Given this list of marker genes CCDC32, ZIC3, CFAP53, CFC1, CIROP, PKD1L1, CPLX1, LETM1, PIGG, CLXN, TBX5, CFAP52, DAW1, ODAD4, NSD2, NELFA, SMAD2, FOXJ1, NODAL, CTBP1, DNAAF5 (NCBI Gene Id 54919), GDF1, ACTG2, CHD6, here is a description of the gene set: Human Gene Set: HP_ABNORMALITY_OF_ABDOMINAL_SITUS Abnormality of abdominal situs An abnormality of the abdominal situs, i.e., of the sidedness of the abdomen and its organs. species: Homo sapiens